The following is a description of a gene set: Any process that modulates the rate or extent of progression through the cell cycle. species: Mus musculus Mouse Gene Set: GOBP_REGULATION_OF_CELL_CYCLE, and this is the list of marker genes: Wdr76, Rps6kb1, Pum1, Tmod3, Ticrr, Lmnb1, D7Ertd443e, Rptor, Bcr, Cdkn2b, Setmar, Hmgb1, Cdk12, Cdk16, Zfyve26, E2f5, Sox15, Fbxo4, Anapc2 (NCBI Gene Id 99152), Rxfp3, Sstr5, Ranbp1, Adarb1, Parp3, Tada3, Apex1, Ankrd31, Mbip, Plcb1, Cdk14, Rack1, Plpp2, Ccar2, Mecom, Pmp22, Vax2os, Knstrn, Donson, Nr2e1, Sirt2, Cdc14a, Taok3, Miip, Myog, Cdk5, Lep, Rnf112, Ccpg1, Epc2, Ppp2r1a (protein phosphatase 2, regulatory subunit A, alpha, NCBI Gene Id 76182), Hmga2, Ttc28, Ppp2r5b, Prkacb, Stxbp4, Crebbp, Mir744, Fgfr1, Rad9a, Tsc1, Fgfr3, Cdk13, Cdkn3, Cry1, Dlgap5, Pdik1l, Gata3, Mapk12, Appl2, Paf1, Cdkn2c, Cacnb4, Mastl, Prap1, Zfp703 (zinc finger protein 703), Zfp369, Drd2, Ankrd17, Ccnh, Paxip1, Mdm4, Usp17le, Apbb2, Rad51b, Klhl9, Eml3, Nek2, Kif2c, Kat5, Chmp5, Gjc2, Trim35, Plk3, Cdc5lrt9, Clock, Ppp2ca, E4f1, Chmp4c, Sirt1, Cdc7, Ddit3, Plk2, Nek1, Ttll12, Ttl, Gmnn, Sin3b, Foxo4, Rhob, Sox2, Cenpv, Junb, Wdr12, Dbf4, Tunar, Smarcd3, Rad17, App, Dtx3l, Uvrag, Mbtps2, Ints7, Ereg, Lemd3, Fam83d, Rad18, Xrcc3, Bard1, Ptprk, Ascl1, Bub1, Lsm11, Lrp5, Cts7, Zzz3, Creb3l1, Poldip2, Kif13a, Dpf3, Rdx, Epm2a, Rab11fip3, Etaa1, Eif4g3, Fzd9, Dync1h1, Lats2, Rad51, Myo16, Csnk2a2, Cdk3, Usp47, Prkca, Rad51ap1, Cdkl4, Msx1 (msh homeobox 1), Nherf1, Mta3, Meioc, Brca1, Ptprc, Trp63, Hspa1a (NCBI Gene Id 193740), Appl1, Jade2, Cep97, Ruvbl1, Senp6, Npm2, Wee1, Usp50, Bmal1, Rrp8, Ska3, Ankrd53, Mir26b, Tgfa, Tsg101 (NCBI Gene Id 22088), L3mbtl1, Calm2, Kif2b, Ovol1, Ovol2, Rad51d, Gmnc, Fbxo31, Lats1, Ctc1, Kif11, Rrm2b, Cdc26, Ncapd2, Calr, Usp16, Smarcc1, Cdkn2a, Spata22, Chfr, Ddias, Id2, Ube2b, Xpo1, Trp53i13, Chmp1b, Bin1, Psme1, Tbx2, Hecw2, Wee2, Sin3a, Grb14, Mdc1, Timeless, Kcna5, Spc24, Cdc16, Cep250 (centrosomal protein 250), Nppc, Igf1r, Evi2b, Mrnip, Topbp1, Dact1, Ddb1, Usp51, Rprm, Foxn3, Ppm1g, Mapk14, Bax, Ncapg2, Prkaca, Rint1, Rnf4, Nek10, Sfrp1, Prkcq, Stk33, Gpr3, Cdc25c, Cenpj, Bmp2, Foxg1, Exoc7, Tas2r102, Morf4l1, Tas1r2, Bmyc, Mok, Prox1, Atp2b4, Shb, Mad1l1, Drg1, Trim32, Uba3, Chordc1, Smim22, Dcun1d3, Cdc42, Pdgfb, Rassf1, Pabir1, Gadd45a, Dach1, Rbl2, Fzr1, Mnt, Piwil2, Stk35, Map3k20, Incenp, Fbxo7, Rpl24, Cdkl1, Mdm2, Fhl1, Srpk2 (NCBI Gene Id 22382), Esx1, Tpx2, Tbx20, Csnk2a1, Meis2, Lgmn, Myo19, Ccdc66, Inca1 (NCBI Gene Id 216875), Brinp1, Ythdc2, Trp53, Dyrk3, Brd7, Tsc22d2, Cks2, Nudt6, Neurog1, Gpsm2, Anxa1, Ing5, Cdk7, Hoxa13, Mfn2, Vash1, Ilkap, Bcl7b, Cdc5l, Ccng2, Tal1, Nabp1, Spdl1, Sdcbp, Ccne1, Cdkn1a, Drd3, Tgm1, Irf1, Egfr, Ptpn6, Map3k7, Tpra1, Ahctf1 (AT hook containing transcription factor 1), Prpf40a, Pim3, Zc3h12d, Fancd2, Ccne2, Actr8, Btn2a2, Pik3c3, Tfdp2, Ins1, Cebpa, Dtl, Cdc14b, Hyal1, Nek6, Dusp1, Hspa8, Cdca5, Rpa3, Pdpn, Mov10l1, Cdk11b, Cdk18, Pinx1, Aspm, Foxe3, Mir124a-3, Cep120, Tgfb1, Trrap, Tas2r121, Itgb1, Babam2, Ccnk, Rnaseh2b, Fosl1, Ccnf, Rpa2, Klhl22, Wnt4, Usp19, Ccn2, Atad5, Mrgprb1, Alms1, Tmsb4x, Slc6a4, Azin1, Xpc, Nek11, Ccnb1-ps, Fap (NCBI Gene Id 14089), Fsd1, Kif20a, Sra1, Rad9b, Knl1, Tpr, Nuf2, Mir16-1, Hus1, Birc7, Lrp6, Cdc23, Cdk15, Ooep, Psma8, E2f1, Ins2, Dicer1 (dicer 1, ribonuclease type III), Numa1, Mybbp1a, Ccnd3, Fntb, Cav2, Cdc5lrt8, Ccni (cyclin I), Mapk15, Cks1b, Crlf3, Rad21, Nme6, H2-M3, Trim37, Nusap1, E2f8, Pkhd1, Gpr132, Cit (NCBI Gene Id 320895), Yeats4, Mos, Trim39, Lif, Smarcc2, Wac, Smarcd1, Ccnl2, Chmp4b, Tcim, Rara, Pten, Klhl21, Ppp1r13b, Men1, Cdc5lrt10, Fignl1, Nup214, Birc2, Ino80, Rcc1, Pdgfrb, Dna2, Trp73, Nuggc, Cep192 (NCBI Gene Id 70799), Calm1, Cdk6 (NCBI Gene Id 330039), Cdkl5, Pou4f1 (NCBI Gene Id 78006), Eif4e, Nsun2, Prpf19, Rbm14, Ing4, H2ax, Slf1, Rbbp8, Nup62, Cdca8, Cul9, Ier3, Larp7, Ambra1, Hsf1, Ythdf2, Ndc80, Naa10, Brsk1, Brd8, Ddr2, Tjp3, Khdc3, Jade3, Mad2l1bp, Gen1, Chek1, Timp2, Pkp4, Aurka, Wapl, Cdk19, Mbd4, Pbrm1, Gli1, Nras, Gas1, Parp9, Ints3 (NCBI Gene Id 97059), Myocd, Zfp655, Kntc1, Wfs1, Kif23, Bcl2, Zpr1 (NCBI Gene Id 22687), Kif3b, Chmp2b, Bmp7, Mcidas, Cyp1a1, Dpf2, Becn1, Cenpe, Cep85, Nudt16, Taok1, Eif2ak4, Nupr1, Eme1, Bcl7a, Zwilch, Aatf (apoptosis antagonizing transcription factor), Camk2d, Ccnb1, Ddx3x, Hormad1, Cdc73, Rrm2, Slf2, Nanog, Ppp2r2d, Pik3r4, Hnrnpu, Kmt2e, Ube2c, Jun, Tnks, Nanos3, Ercc2, Pum2, Gdpd5, Gper1, Ankk1, Birc5 (baculoviral IAP repeat-containing 5), Kcnh5, Pdxp, Cdc25b, Insr, Calm3, Dgkz, Nle1, Chmp3, Cep295nl, Mre11a, Igf1, Il10, Skil, Nr4a1, Dctn1, Slfn1, Bub3, Rbm46, Obsl1, Flt3l, Ino80c, Plk1, Ccl12, Tipin, Yy1, Dazl, Eif4ebp1, Git1, Ube2u, Pkp3, Trip13, Tbx1, Il1a, Dab2ip, Rab11fip4 (RAB11 family interacting protein 4 (class II)), Usp22, Dmrt1, Ino80e, Runx3, Stat3, Sgsm3, Mcph1, Ect2, Btc, Cdc5lrt1, Gas2, Fgf10, Aicda, Ercc3, Cltc, Asah2, Hdac3, Smarce1, Wiz, Rhno1, Mettl13, Sphk1, Nek9, Pkn2, Tacc3 (transforming, acidic coiled-coil containing protein 3), Btg4, Chmp1b2, Cul3, Ptprv, Rae1, Ecd, Tnf, Cdk5rap1, Stk38, Insm1, Hspa1b, Apbb3, Gadd45g, Tada2a, Brcc3dc, Hpgd, Ccsap (centriole, cilia and spindle associated protein), Six3, Poc5, Tent5b (terminal nucleotidyltransferase 5B), Trex1, Nkx3-1, Foxc1, Akt1, Inhba, Pkd2, Map9 (NCBI Gene Id 75994), Prmt2, Rgcc, Rps15a, Lyn, Diaph3, Ruvbl2, Hus1b, Nae1, Clspn, Syf2, Nop53, Fgf8, Hacd1, Sgf29, Mblac1, Cxcr5, Hepacam, Inha, Tfpt, Znhit1, Pdcd6ip, Scrib, Pkmyt1, Zmpste24, Tert (telomerase reverse transcriptase), Smarca5 (SWI/SNF related, matrix associated, actin dependent regulator of chromatin, subfamily a, member 5), Fzd3, Nfe2l1, Ets1, Cyld, Stil, Pml, Abl1, Foxa1, Angel2, Epgn, Osm (NCBI Gene Id 18413), Cdk5rap3, Tas2r124, Edn3, Ep400, Spdye4a, Tfdp1, Cgrrf1, Taf6, E2f7, Ctdspl, Nanos2, Tfap4, Cops5 (NCBI Gene Id 98296), Actb, Phactr4, Plaat3, Ufl1, Psmd10, E2f4, Tbrg1, Ube2e2, Susd2, Aurkb, Asns, Camk2b, Ccp110, Ywhae, Cables1, Rab11a, Smc5, Cdk2, Sass6, Rb1, Bora, Plscr1, Gpr15lg, Hnf4a, Atm, Tubg1, Trp53bp1, Wdr62, Rock2, Fbxo43, Ttk, Btg3, Anapc5, Pim1, Tom1l1, Mapre3, Mad2l1, Ctdsp1, Nfrkb, Dpf1, Inip, Arf6, Tcf3, Sh3glb1, Plcg2, Aurkc, Racgap1, Gnai1, Phb2, Brcc3, Bop1, BC005624, Iho1, Pim2, Acvr1, Ino80b, Tti1, Bap1 (Brca1 associated protein 1), Dync1li1, Mepce, Pclaf, Bcl7c, Son, Cdk4, Pebp1, Kat14, Phf10, Mus81, Rad50, Prkdc, Tmem67, Bcl2l11, Adam17, Rmi2, Mrgbp, Kif20b, Cd28, Cdc27, Nek7, Pggt1b, Nat10, Cenpf, Cks1brt, Mir214 (NCBI Gene Id 387210), Uhmk1, Kat7, Bcl2l1, Ccdc8, Cdkn1b, Chek2, Alox8, Rad1, Sgo2a, Hes1, Csf1r, Bak1, Kat2a, Rpl17, Ctnnb1, Tiprl, Anapc7, Nr4a3, Adamts1, Psrc1, Eif4g1, Tbx3, Il1b, Smc6, Pin1, Lef1, Usp2, Ppp1r35, BC004004, Ccng1, Ywhah, Chmp7, Prc1, Cdc5lrt4, Tm4sf5, Madd, Esr1, Uimc1, Pde3a, Cirbp, Mnat1, Gbf1, Hinfp, Cdkn2d, Hspa2 (NCBI Gene Id 15512), Insm2, Cdk10, Ubd, Kank2, Hras, Prr11, Suv39h1, Anapc15, Wnt5a, Ubxn2b, Cul7, Atrx, Jund, Adcyap1, Krtap21-1, Mir26a-2, Cpsf3, Ppp2r3d, Plk5, Birc6, Nsmce2, Snd1, Smarca2, Iqgap1, Klf4, Sipa1, Tgfb2, Ncaph, Smc2, Nsfl1c, Usp28, Ptpn11, Nubp1, Recql4 (NCBI Gene Id 79456), Fem1b, Ints13, Ercc6, Dmap1, Uchl5, Ccdc57, Msx2, E2f2, Spdya, Ncaph2, Spag5, Kifc1, Gigyf2, Gadd45b, Bub1b, Cited2, Mark4, Brca2, Dusp3, Cdc5lrt7, Epc1, Atf5, Ddx11, Zfp207, Spc25, Atrip, Khdrbs1, Sfpq, Nbn, Stra8, Rnf167, Smpd3, Cdk2ap2 (cyclin dependent kinase 2 associated protein 2), Pcid2, Tex14, Cdc20, Lin9, Apbb1 (NCBI Gene Id 11785), Klhl13, Rps6, Myc, Uhrf2, Ncapd3, Dlg1, Zfp830, Blm, Ska1, Msh2 (mutS homolog 2), Cep295, Gata4, Rhoa, Mir26a-1, Cspp1, Zw10 (zw10 kinetochore protein), Smarcd2 (SWI/SNF related, matrix associated, actin dependent regulator of chromatin, subfamily d, member 2), Jade1, Cdk8, Rad51c, Fen1, Senp2, Arid2, Baz1b, Rps27l, Cdk5rap2, Brinp2, Fnta, Chmp2a, Arhgap33os, Prpf4b, Gpnmb, Btrc, Rprd1b, Cdc6, Morf4l2, Cdca2, Ing3, Mbtps1, Yeats2 (YEATS domain containing 2), Bmp4, Vps4b, Bex4, Zbtb49 (zinc finger and BTB domain containing 49), Mdm1, Cep76, Nabp2, Zwint, Mki67, Psmg2, Svil, Cdkl2, Cdk1, Cables2, Ptpn3 (NCBI Gene Id 545622), Rpl23, Macroh2a1, Sde2, Stat5b, Actl6a, Cdk17, Dapk3, Med1, Gnb1l, Sh2b1, Prdm9, Pes1, D1Pas1, Meiosin, Riok2, Kcnn4, Tardbp, Ifnz, Sox9, Babam1, Cntd1, Chtf18, Wdr5, Poc1b, Rbl1, Lcmt1, Brd4, Trim36, Anapc4, Mtbp, Igf2 (NCBI Gene Id 16002), Haspin, Actr5, Ccnq, Smoc2, Rad23a, Nf2, Smc4, Wnk1, Hexim2, Orc1, Ccnl1, Pbx1, Cdc25a, Aif1 (NCBI Gene Id 56250), Kif14, Anapc11, Axin2, Ccnd2, Xiap, Lsm10, Fgfr2, Smarcb1, Cep131, Rcc2, Cul4b (NCBI Gene Id 72584), Eme2, Sik1, Dyrk1a, Anapc1, Dynlt3, Ptch1, Edn1, Rbm38, Cdt1, Pafah1b1, Bid, Cdkn1c, Cep63, Lfng, Afap1l2, Hsp90ab1, Cetn2, Plk4, Stox1, Ino80d, Prkce, Cdkl3, Cgref1 (NCBI Gene Id 68567), Mcrs1, Mlf1, Poc1a, Ccny, Vps4a, Znrf4, Gja1, Cenatac, Psme3, Ripor2, Skp2, Map10, AY074887, Cul4a, Bbs4, Txlng, Spice1, Atr, Mir124a-2, Nupr2, Tom1l2, Celf1, Tsc2, Ezh2, Prcc, Vps72, Ccnd1, Psme2, Plrg1, Usp44, Ppp1r10, Trnp1, Zfp36l1, Pkd1, Klf11, Wnt10b, Mettl3, Anapc15-ps (anaphase promoting complex C subunit 15, pseudogene), Npr2, Per2, Pnpt1, Rps6ka2, Brinp3, Actl6b, Cdk20, Abraxas1, Setd2, Ppp2r2a, Thap1, Pkia, Met, Mir124a-1, Fbxw5, Cdc5lrt6, Spast, Mn1, Egf, Klhl18, Sfn, Crnn (NCBI Gene Id 630883), Entr1 (endosome associated trafficking regulator 1), Meaf6, Apc, Prdm11, Foxk1, Chmp1a, Ik, Ccdc15, Rfwd3, Tnfaip3, Kat2b, Ctbp1, Phip, Nr2f2, Heca, Atf2, Fbxo5, Pagr1a, Gipc1, Mapk8, Aven, Atxn10, Zfyve19, Cdc5lrt5, Rrm1, Stat5a, Arid1a, Hhex, Birc3, Dot1l, Smarca4, Zfp36l2, Fam107a, Zfy2, Grk5, Casp3, Anp32b, Cdk9, Chmp6, Mbtd1, Ptgs2, Foxm1, Ctdsp2, Taok2, Trim21, Npm1, Fgf2, Dr1